The following is a description of a gene set: species: Homo sapiens Human Gene Set: chr9p13, and this is the list of marker genes: MYORG, ENSG00000187186, TUBB4BP2, HINT2, ENSG00000287838, UBE2R2-AS1, TMEM8B, FANCG, RNU4-53P, FAM240B, SPATA31F1, ARMC8P1, RPP25L, FRMPD1, UBAP1, ANXA2P2, DCAF10, TRBV24OR9-2, PAICSP1, GBA2, RPS29P17, TPM2 (tropomyosin 2), ZFAND6P1, GLULP4, PRSS3, PRSS3P4, RPL35AP2, YBX1P10, MELK, FBXO10, MIR6853, RN7SL338P, TESK1, SNORD121A, RNF38, BAG1, RUSC2, IGFBPL1, STOML2, FAM219A, SIT1 (NCBI Gene Id 27240), ENSG00000233242, RPL36AP33, PTENP1-AS, ARHGEF39 (NCBI Gene Id 84904), MIR4475, UNC13B, ANKRD18B, RNU6-677P, FAM201A, CHCHD4P3, AQP3, TLN1, MIR4540, CREB3, CCL19, LINC01400, GAS2L1P1, MSMP, VCP, ENSG00000227933, OR2S2, EBLN3P, LINC01627, CLTA, CD72, TRBV23OR9-2, FAM221B, TRBV29OR9-2, SNX18P3, CYP4F33P, SERPINH1P1, NFX1, GNE, MIR4476, RPL21P83, CCL27, PHF24, KCTD9P3, RN7SL22P, CIMIP2B, PAX5, VN1R48P, PIGO-AS1, SPATA31G1, SPAG8 (sperm associated antigen 8), ZBTB5, TRMT10B, DCTN3, CHMP5, PIGO, ZCCHC7, GLIPR2, RN7SKP114, ENHO, ENSG00000287514, RN7SKP24, PTENP1, DNAJB5 (NCBI Gene Id 25822), CYP4F26P, GRHPR, YWHAZP6, RGP1, TRBV25OR9-2, CNTFR, IL11RA, SPATA31F2P (SPATA31 subfamily F member 2, pseudogene), UBE2R2, OR13C7, ANKRD18A (NCBI Gene Id 253650), ATP8B5P, TCEA1P3, SNORD121B, SLC25A51, ALDH1B1, CCDC107, MIR6852, KIF24, RNU6-765P, TRBV26OR9-2, ARID3C, YWHABP1, TRBV21OR9-2, SNX18P7, CA9, SYF2P2, SUGT1P1, CNTFR-AS1, EXOSC3, RECK, ENSG00000286322, RN7SKP171, RPL32P21, MIR6851, NDUFA5P4, ENSG00000305767, SPATA31F3, RNU7-124P, NPR2, RAB1C, OR2AM1P, UBAP2, NUDT2 (NCBI Gene Id 318), PGAM1P2, DCAF12 (NCBI Gene Id 25853), TMX2P1, OR13J1, DNAJB5-DT, OR13E1P, SIGMAR1, RNA5SP282, AQP7, TRBV22OR9-2, ENSG00000200026, ENSG00000309109, RNU2-50P, RMRP, FAM220BP, HRCT1, SPINK4, ATOSB, OR2S1P, OSTCP8, OR13C6P, MIR4667 (NCBI Gene Id 100616214), SPAAR (NCBI Gene Id 158376), SHB, TOMM5, SPMIP6, TRBV20OR9-2, GALT, RNU4ATAC11P, DNAI1, HMGB3P24, POLR1E, NOL6, CCL21, CCIN